Given this list of marker genes F13A1, EXO1, PLK4, KLHDC2, ITIH5, SRGAP3 (NCBI Gene Id 9901), EEA1, PBK, TFEC, FANCC, BRCA1, CXCL10, FPR1, IFI44, IL1R2, TRPS1, CYP20A1, UBASH3B, PLXDC2, NAMPT, TRAM2, MS4A3, IL1RL1, AREG, SPC24, MXD1, STX11 (NCBI Gene Id 8676), CBLB, TAF4B, HAUS7 (NCBI Gene Id 55559), IRF7, LCLAT1, MPO, PTCH1, CD160, HNRNPLL, ARHGAP21, HIF1A, ETS2, SULT2B1, PPP1R16B, HEXIM1, CDC14A, IFNGR1, MFSD2A, PRTN3, CAPG, NDRG1, SPATS2, STAT3, CD38, IFI30, KIF18A, NINJ2, TRIM5, TFDP2, TUBGCP2 (NCBI Gene Id 10844), PDCD1, GSTO1, ISOC1, SYCE2 (synaptonemal complex central element protein 2), DUSP16, SAA3P, MIR15A, RSAD2 (NCBI Gene Id 91543), BCL2L11 (NCBI Gene Id 150819), BST1, IFI16, MAFF, RIGI, CPT1A, NR4A1, UFD1, PACSIN1, IL6ST, SLC25A36 (NCBI Gene Id 55186), MT2A, SPIN2A, TNFRSF18, ITM2A, HIPK2, ATAD5, TMBIM4, SHMT1, CCL2, PHLDA1, ADAM9, SKAP2, TOX, PLIN2 (perilipin 2), CEP170, METTL2B, USP6NL, ROM1, FILIP1 (filamin A interacting protein 1, NCBI Gene Id 27145), TBC1D19, CD180, P2RY13, BIRC3 (baculoviral IAP repeat containing 3), MYB, NFIL3, IER2, TNFRSF4, RTP4, SETBP1 (NCBI Gene Id 284262), ENTPD1, HEG1, CD44, XCL1, IRF4, RNF125, MT1A, G6PC3, NEB, EIF2AK2, VCAN (NCBI Gene Id 7902), GPR146, TNFRSF9, PARP12, PI4K2B, SOCS4, SYT11, TWSG1, CTLA4, LITAF, LY6S, IFIT3, FGL2, TGIF1, PDE7B, ISG20, NHLRC3, CCRL2, TIGIT, FAM3C, OCIAD2, BST2, TLR7, HELLS, ARRDC4, CCDC134, CXCR4, BATF, CCNYL1, RGS16, PDE4D, MDFIC, TPD52, PMF1 (NCBI Gene Id 94958), NEURL3, TRPC1, RPAP3, ORC1, RABGAP1L, CABLES1, FABP7 (fatty acid binding protein 7), CCR9, SERPINB9, ZC3H12C, here is a description of the gene set: from publication Zhang X, Jin J, Tang Y, Speer D, Sujkowska D, Markovic-Plese S (PMID 19265172) IFNβ, an effective therapy against relapsing-remitting (RR) multiple sclerosis (MS) is naturally secreted during the innate immune response against viral pathogens. The objective of this study was to characterize the immunomodulatory mechanisms of IFNβ targeting innate immune response and their effects on DC-mediated regulation of T-cell differentiation. We found that IFNβ−1a in-vitro treatment of human monocyte-derived dendritic cells (DCs) induced the expression of TLR7 and the members of its downstream signaling pathway, including myeloid differentiation factor 88 (MyD88), IL-1R-associated kinase (IRAK)4, and TNF receptor-associated factor (TRAF)6, while it inhibited the expression of IL-1R. Using siRNA TLR7 gene silencing, we confirmed that IFNβ-1a-induced changes in MyD88, IRAK4 and IL-1R expression were dependent on TLR7. TLR7 expression was also necessary for the IFNβ-1a-induced inhibition of IL-1β and IL-23, and the induction of IL-27 secretion by DCs. Supernatant (SN) transfer experiments confirmed that IFNβ-1a-induced changes in DCs’ cytokine secretion inhibit Th17 cell differentiation as evidenced by the inhibition of retinoic acid-related orphan nuclear hormone receptor C (RORC) and IL-17A gene expression and IL-17A secretion. Our study has identified a novel therapeutic mechanism of IFNβ−1a, that selectively targets the autoimmune response in MS. Human Gene Set: GSE14386_UNTREATED_VS_IFNA_TREATED_ACT_PBMC_MS_PATIENT_DN studied in species Homo sapiens Genes down-regulated in peripheral blood mononclear cells (PBMC) from multiple sclerosis (MS) patient: untreated versus IFNB1.